The following is a description of a gene set: Reactome Pathway: Ras activation upon Ca2+ influx through NMDA receptor studied in species Homo sapiens part of: CREB1 phosphorylation through NMDA receptor-mediated activation of RAS signaling Ca2+ influx through the NMDA receptor triggers RAS signaling through the activation of RAS guanyl nucleotide exchange factor RasGRF., and this is the list of marker genes: RASGRF1, DLG4, RASGRF2, NRAS, DLG2, ACTN2, KRAS (KRAS proto-oncogene, GTPase), LRRC7 (leucine rich repeat containing 7), CAMK2A, GRIN2D, DLG3, NEFL, HRAS, GRIN2B, CAMK2B, CAMK2G (NCBI Gene Id 818), CAMK2D, GRIN1, DLG1, CALM1